The following is a description of a gene set: species: Homo sapiens Genes having at least one occurrence of the motif DCCWTATATGGNCWN in the regions spanning 4 kb centered on their transcription starting sites. This matches the SRF transcription factor binding site V$SRF_C (v7.4 TRANSFAC). Human Gene Set: SRF_C, and this is the list of marker genes: ITGB6 (integrin subunit beta 6), GRK6, RGS3 (NCBI Gene Id 5998), CA3, CALD1, DEFB129, SCOC, ACTC1, EGR2, PFN1, TSPAN2, WDR81, TLE3, EFHD1, MAP3K20, LMCD1, TADA3 (transcriptional adaptor 3), NR2F2, KCNK3, DMD, MYO1B, BCAS3, JUNB, ADGRG4, RAB30, MCAM, PADI2, CNN2, PRKAB2, MYL6 (myosin light chain 6), IRAG1, DUSP2, RASD2, YWHAZ, HAPSTR1, MIR22HG, DIXDC1, HOXD10, CD248, AOC3, SUN2, MYLK, MYL7, PNKP, CLEC18C, RSF1, ZNF408, EVA1C, FBXL22, TANK, ZNF644, KRTCAP2, UNC45B, SETD2, MRGPRF, DNAJB4, ITGB1BP2, ACTG2, CAP1, CTNND1, AAMDC, AKAP12 (NCBI Gene Id 9614), IL17B, MEIS1, JPH2, LTBP1 (latent transforming growth factor beta binding protein 1), PLN, SYNCRIP, LPP, DSTN, DLL1, STAT5B, TMEM47, PLCB3, FLNA, IGF2-AS, LCP1, PPP2R3A, GGN, ROCK2, ZNF513, DUSP5, ABL1, PAN2, CDC14A, COL8A1, VCL, MAPK14, MUS81, RSU1, XK, GPR20 (G protein-coupled receptor 20), SLC2A4, FOS, FGFRL1, PHF12, FOXE3, AARSD1 (alanyl-tRNA synthetase domain containing 1), POU3F4, PDLIM4, PATL1, RRM1, HERC1, FOSB, SLC25A4, KLF6, TAFAZZIN, SPAG7, CFL2, SUSD1, PDLIM7 (PDZ and LIM domain 7), FOXP1, DCUN1D3, ANAPC15 (NCBI Gene Id 25906), ACVR1, CRK, RNF39, ACTA1, HOXA3, DACT3, RBBP7, KCTD15, MITF, TRIM55, MATR3, TRIM46, NKX2-1, ERBIN, TNNC1 (troponin C1, slow skeletal and cardiac type), MYH11, CFL1, CKM, SYT9, ARPC4, NR2F1, NKX6-2, COL1A2, THBS1, NKX2-2, MYO1E, STARD13, DUSP6, POPDC2, SIPA1, MYO18B, NR4A1, FHL2, HOXB4, TOP1, NPAS4, SSH3, FOXP2, NPAS2, STX10, RHOJ, ANXA6, ZEB2, KALRN, DVL3, ELAVL4, HNF1B, LRP5, HOXB5, GADD45G, SRF, PDLIM5, TUFT1, RASSF2, PPP1R12A, GFPT2, DMPK, LYRM1, MBNL1, ACTN1, IER2, TFAP2D, EML4, ITGA7, CNN1, SLC7A1, MYL9, RUNDC1, TAGLN, ARHGAP1, PRUNE2, DUSP10, HOXA5, ACTR3 (NCBI Gene Id 10096), KCNMB1, CCN1, LIN28A, TGFB1I1, YRDC, MAP1A, OSM (NCBI Gene Id 5008), EGR3, PTCH1, G3BP2, EGR4, EGR1, FOSL1, PRM1, SRD5A2, EMILIN2, CACNA1B, LDB3, ASPA, DAPK3, ASB2, TPM3, AAK1, ACTB, PRR14L, FAM53C, MANEAL